The following is a description of a gene set: Any process that stops, prevents or reduces the frequency, rate or extent of alcohol biosynthetic process. studied in species Homo sapiens Human Gene Set: GOBP_NEGATIVE_REGULATION_OF_ALCOHOL_BIOSYNTHETIC_PROCESS, and this is the list of marker genes: REST, MIR30C1, MIR185, PRKG1, PLEK, INSIG1, APOE (NCBI Gene Id 99), ERLIN1, MIR342, BMP5, DKK3, C7orf50, BMP2, MIR548P, MIR98, ERLIN2, SCAP (NCBI Gene Id 22937)